The following is a description of a gene set: Trichorrhexis nodosa is the formation of nodes along the hair shaft through which breakage readily occurs. It is thus a focal defect in the hair fiber that is characterized by thickening or weak points (nodes) that cause the hair to break off easily. The result is defective, abnormally fragile hair. species: Homo sapiens Human Gene Set: HP_TRICHORRHEXIS_NODOSA Trichorrhexis nodosa, and this is the list of marker genes: HEPHL1, MPLKIP, SKIC3, CLCN6, KDF1, GTF2H5, AARS1, KRT25, SKIC2, ERCC2, SPINK5, GJA1, ASL